Given this list of marker genes PRF1, ATP8B3, CLGN, PCDHA7, TEX101, CD81, ACR, ADAM32 (NCBI Gene Id 203102), LY6K, PRSS55, CCT4, CD6, HSPA1L, CD209, FOLR1, ADAM2, TCP1, ST6GALNAC6, FUT3, PCSK4, SPACA4, ALDOA, TMEM81, ASTL, CCT8, TMPRSS12, DOCK2, GIT1, ZP4, FOLR3, SPA17, PAEP (progestagen associated endometrial protein), PRSS37, LGALS3, DCST1, CCL21, DOCK8, UBAP2L, CD2AP (CD2 associated protein), SPPL2C, SPESP1, ZPBP2, CCT5, ZAN, SPACA6 (NCBI Gene Id 730718), IZUMO1R (IZUMO1 receptor, JUNO), NCK2, CCR7, DLG1, EPHB1, CLEC4M, IZUMO1, NEDD9, CCT3, CRISP1, PCDHB6, CCT7, B4GALT1, SPACA3, DCST2, ZP3, FETUB, CCT2, ZPBP, VDAC2, FREY1 (NCBI Gene Id 143678), ZP1, CD9, CORO1A, MSN, CCL19, GARIN3, ADAM18, FOLR2, ZP2, SPAM1, HAVCR2, OVGP1, here is a description of the gene set: Human Gene Set: GOBP_CELL_CELL_RECOGNITION species: Homo sapiens Cell recognition between cells. May involve the formation of specialized cell junctions.